Given this list of marker genes KIAA0753, RSPO2, FLNB, COL2A1, LAMA5, LBR, B3GALT6, RNU4ATAC, SPARC, CCN2, here is a description of the gene set: Human Gene Set: HP_BOWED_HUMERUS A bending or abnormal curvature of the humerus. Bowed humerus species: Homo sapiens